The following is a description of a gene set: Mouse Gene Set: REACTOME_MITOPHAGY Mitophagy species: Mus musculus, and this is the list of marker genes: Tomm6, Csnk2a1, Ubc, Pgam5, Ube2v1, Atg12, Tomm5, Src, Ube2n, Uba52rt, Atg5, Ube2d3, Uba52, Rps27a, Map1lc3a, Csnk2b, Fundc1, Mfn1 (NCBI Gene Id 69518), Ube2d2a, Vdac2, Ubb, Tbk1, Map1lc3b, Pink1, Vdac1, Tomm20 (NCBI Gene Id 67952), Csnk2a2, Mfn2, Ube2l3, Mterf3, Optn, Prkn, Tomm70a, Ulk1, Tomm22, Atg9a, Tomm7, Sqstm1, Tomm40, Vdac3